The following is a description of a gene set: Catalysis of chain elongation of prenyl diphosphate substrates via one or more condensation reactions with isopentenyl diphosphate to generate linear polymers with defined chain lengths. Human Gene Set: GOMF_PRENYL_DIPHOSPHATE_SYNTHASE_ACTIVITY species: Homo sapiens, and this is the list of marker genes: COX10, NUS1, PDSS1, GGPS1, PDSS2, FDPS, DHDDS